The following is a description of a gene set: Any process that activates or increases the frequency, rate, or extent of cellular extravasation. species: Mus musculus Mouse Gene Set: GOBP_POSITIVE_REGULATION_OF_CELLULAR_EXTRAVASATION, and this is the list of marker genes: Lyve1, Med23, Ccl2, Ptger4, Thy1, Jam3, Il1r1, Ccr2, Mdk, Ager, Pecam1, Fadd, Icam1, Pawr, Adam8, Cd99l2, Ripor2, Ptafr, Pdgfd, Ptger3, Cd47, Plvap